Given this list of marker genes NPAS3, SNURF, GOLGA2, PAK2, DAB2, CCDC102B, DRD5, PARP8, TTF2, RUNX2, ICOS, TMEM178B, NF1 (NCBI Gene Id 646021), GPR88, MAPK9 (NCBI Gene Id 5601), HERC1, HNRNPA2B1, ITGBL1, TLR4, SDC3, VWC2, ABI1, DPH3, DUSP4, ZNF182, TRPA1, C1orf115, NRCAM (neuronal cell adhesion molecule), EGFL6, KCNK12, PAPLN, ZBTB10, NSF, SMIM43, MAPK10 (NCBI Gene Id 5602), CLDND1, MAP3K20, RFPL4B, COL22A1, ATP2A2, SNRPN, PIK3CB, MOB1A, DSG2, RLBP1 (retinaldehyde binding protein 1), GNS, NPL, RTN3, MFNG, MMP1, SGIP1, MAP4K4, FRAS1, COL2A1, B3GALT1, DUSP3, ZNF215, NSUN7, NFASC, ZNF652, HDDC3, RNF170 (NCBI Gene Id 96586), ESPN, DAP, PDCD7, GAN, STXBP5, SLC17A1, UMPS, SESN3, CLCC1, TET3, here is a description of the gene set: from publication Chen Y, Wang X (PMID 31504780) Genes predicted to be targets of miRBase v22 microRNA hsa-miR-6857-3p in miRDB v6.0 with MirTarget v4 prediction scores > 80 (high confidence targets). species: Homo sapiens Human Gene Set: MIR6857_3P